Given this list of marker genes CLN3, NR1H2, STX1B, CAV1, AXL, APPL2, PPT1, PROM2, NR1H3 (nuclear receptor subfamily 1 group H member 3), APPL1, ANKFY1, CDC42, here is a description of the gene set: Any process that modulates the frequency, rate or extent of pinocytosis. Pinocytosis is the process in which cells take in liquid material from their external environment; literally 'cell drinking'. Liquid is enclosed in vesicles, formed by invagination of the plasma membrane. These vesicles then move into the cell and pass their contents to endosomes. Human Gene Set: GOBP_REGULATION_OF_PINOCYTOSIS species: Homo sapiens